Given this list of marker genes Ptprs, Apoe, Hpse2, Comp, Tnc, Col5a1, Hrg, Ptn, Mfn2, Psg17, Itgam, Fcnb, Cfhr4, Ptprc, Psg22, Atp1a3, Ctsk, Col5a3, Lipc (NCBI Gene Id 15450), Lrrtm4, Fbln7, App, Nid1, Ptprf, Agrn (agrin), Cfh, Gpnmb, Psg23 (pregnancy-specific beta-1-glycoprotein 23), Fn1, Chrd, Hpse, Pla2g2d, Ctss, Ctsl, Nf1, Slit2, Col2a1, Lpl, Fst, Ctsb, Sema5a, Slit1, Grem1, Sdcbp, here is a description of the gene set: Binding to a proteoglycan, any glycoprotein in which the carbohydrate units are glycosaminoglycans. Mouse Gene Set: GOMF_PROTEOGLYCAN_BINDING studied in species Mus musculus